Given this list of marker genes DUS1L (NCBI Gene Id 64118), MAP2K2, DLEC1, UQCRC1, PHGDH, JMJD6, CUEDC2, CYC1 (cytochrome c1), BID, PDXK, RPSA, PI4KAP1, NDUFS7, SCO2, MRPS12, NAA10, FAHD2A, ZNF593, DEAF1, MRPL23, NT5DC2 (5'-nucleotidase domain containing 2), POLR2L, MRPS11, DNTTIP2, HSD17B10, PPP1R7, WDR74, NDUFS8, ETFB, UFC1, NOP53, CHAF1A, PITRM1, NQO2, PRPF40A, NOL7, NARF, HSP90B1, BAZ1A, HMOX2, EEF1D, AP2S1, PPIB, MYG1, MRPL12, SRRM2, NOP56, LSM3, ENO1, TSPAN31, TPR, RUVBL2, TST, GATAD1, PSMC3, DGCR6, ELOB, DCXR, ADA (adenosine deaminase), TRAPPC2L, EDF1, MRTO4, BHLHE40, EXOSC4, TACO1, SPEN, EIF3G, SAP30BP, SMC3, NAA15, IDH3G, TRIB3, WDR45, TTC3, ACBD3, MTX1, CHMP2A, APRT, UBXN6, PSMC5, NME6, LBHD1, RFC2, NDUFB7, FLII, NDUFA13, APEH, FAM50A, RPS5, here is a description of the gene set: studied in species Homo sapiens Genes encoding mRNA transcripts specifically bound by DCP2. mRNA decapping is a critical step in the control of mRNA stability and gene expression and is carried out by the Dcp2 decapping enzyme. Dcp2 is an RNA binding protein that must bind RNA in order to recognize the cap for hydrolysis. We demonstrate that human Dcp2 (hDcp2) preferentially binds to a subset of mRNAs and identify sequences at the 5' terminus of the mRNA encoding Rrp41, a core subunit component of the RNA exosome, as a specific hDcp2 substrate. A 60-nucleotide element at the 5' end of Rrp41 mRNA was identified and shown to confer more efficient decapping on a heterologous RNA both in vitro and upon transfection into cells. Moreover, reduction of hDcp2 protein levels in cells resulted in a selective stabilization of the Rrp41 mRNA, confirming it as a downstream target of hDcp2 regulation. These findings demonstrate that hDcp2 can specifically bind to and regulate the stability of a subset of mRNAs, and its intriguing regulation of the 3'-to-5' exonuclease exosome subunit suggests a potential interplay between 5'-end mRNA decapping and 3'-end mRNA decay. from publication Li Y, Song MG, Kiledjian M (PMID 18039849) Human Gene Set: LI_DCP2_BOUND_MRNA